The following is a description of a gene set: Human Gene Set: WP_DEVELOPMENT_AND_HETEROGENEITY_OF_THE_ILC_FAMILY Development and heterogeneity of the ILC family species: Homo sapiens, and this is the list of marker genes: IL13, IL4, IL6, IL1B (interleukin 1 beta, NCBI Gene Id 3553), IL5, NFIL3 (NCBI Gene Id 4783), TBX21, GFI1, IL17A, RORA, IL33, IL12A, IL15, RORC, AREG, AHR, TSLP, IL22, TNF, ID2, IL25, GATA3, TOX, IFNG, IL23A (interleukin 23 subunit alpha), BCL11B, ZBTB16, IL18, IL7, IL12B, EOMES, IL9, HNF1A (HNF1 homeobox A, NCBI Gene Id 6927)